Given this list of marker genes Prmt5, Chek2, Ehmt1, L3mbtl1, Atm, Ubc, Smyd2, Jmy, Ehmt2, Mdm2, Uba52, Trp53, Mdm4 (transformed mouse 3T3 cell double minute 4), Rps27a, Uba52rt, Kmt5a, Ttc5, Ubb, Ep300, here is a description of the gene set: Mouse Gene Set: REACTOME_REGULATION_OF_TP53_ACTIVITY_THROUGH_METHYLATION Regulation of TP53 Activity through Methylation studied in species Mus musculus